Given this list of marker genes Hadha, Acat1, Acat2, Acaa1a, Acat3, Scp2, Acaa2, Hadhb, Acaa1b, here is a description of the gene set: Mouse Gene Set: GOMF_ACETYL_COA_C_ACYLTRANSFERASE_ACTIVITY species: Mus musculus Catalysis of the reaction: acyl-CoA + acetyl-CoA = CoA + 3-oxoacyl-CoA.